Given this list of marker genes Rab11fip3, Kif20b, Ect2, Rab11a, Exoc7, Nup62, Arf6, here is a description of the gene set: studied in species Mus musculus Mouse Gene Set: GOBP_REGULATION_OF_CYTOKINETIC_PROCESS Any process that modulates the frequency, rate or extent of a cytokinetic process.